Given this list of marker genes Pbrm1, Mis18a, Riok3, Daam1, Lin52, Cdk5r1, Igf1, Shprh, Kdm6a, Arhgap15, Slitrk6, Ica1l, Gata3, Hecw2, Pnrc1, Srgap1, Tspan3, Iws1, Ms4a4b, Rfx7, Plscr2, Frmd5, Suco, Tnrc6c, Cntrob, Chd2, Serpinb9d, Zfp446, Zmynd11, Zfp738, Trhde, Ugt8a, Cask, Rnf44, Stag2 (NCBI Gene Id 78442), Lin9 (lin-9 DREAM MuvB core complex component), Odad2, Rab27a, Carf, Ccdc169, Cnot6l, Dtna, Cracd, Vcf1, Etl4, Csnk1g3, Mei4, Lemd3, Kat7, Ewsr1, Apbb2, Tns3, Pdgfrl, Zfp804a, Ino80d (NCBI Gene Id 329170), Sox9, Sp1, Cyp2b23, Pdcd6ip, Map10, Gnl3l, Arsj, Comtd1, Dusp16, AI597479, Insm2, Synpr, Zfp729b, Khdrbs1, Lcorl, Pes1, Negr1, Pfkfb2, Phip, Acap2 (NCBI Gene Id 78618), Zfp612, Skint10, Trmt2a, Rerg, Gabra2, Smarca5, Wwtr1, Ehf, Cmah, Zfp65, Lrrc8c, Lin28b (NCBI Gene Id 69965), Tpbpa, Kat6a, Macir, Rnf214, B3galt2, Crebzf, Hivep1, Tubgcp5, Cxcl10, Trpm3, Psma2, Insyn2b, Fsd1l, Tbpl2, Unk, Gad2, Cetn3, Neurog2, Rab11a (RAB11A, member RAS oncogene family), Ubtd2, Zfp715, Asxl2, Sntg1, 2310030G06Rik, Zfp36l2, Eps15, Gnpda2, Upp2, Apool, Brms1l (breast cancer metastasis-suppressor 1-like), Zfp503, Or52n4, Bpnt2, Abi2, Klf6, Six6, Psd3, Snai2, Hoxd1, Zcchc18, Dennd4a, Ap3s1, Eme1, Mycbp, Zbtb44 (zinc finger and BTB domain containing 44), Phf20, A630001G21Rik, Cul3, Psmc6, Agbl3 (ATP/GTP binding protein-like 3), Srsf3, Snx27, Slc16a9, Zbtb18, Hook3, Krit1, Rasa2, Akap7, Ube3a, Npm1 (nucleophosmin 1), Dhrs7, Birc6, Arl14ep, 2010106E10Rik, Gabrq (NCBI Gene Id 57249), Irf2bp2 (NCBI Gene Id 672960), Nwd2, Pds5b, Ikzf5, Nup35, Ppp1r21, Dcx, here is a description of the gene set: Genes predicted to be targets of miRBase v22 microRNA mmu_miR_1b_5p in miRDB v6.0 with MirTarget v4 prediction scores > 80 (high confidence targets). Mouse Gene Set: MIR_1B_5P from publication Chen Y, Wang X (PMID 31504780) studied in species Mus musculus